The following is a description of a gene set: This event has been computationally inferred from an event that has been demonstrated in another species.<p>The inference is based on the homology mapping from PANTHER. Briefly, reactions for which all involved PhysicalEntities (in input, output and catalyst) have a mapped orthologue/paralogue (for complexes at least 75% of components must have a mapping) are inferred to the other species. studied in species Mus musculus electronically inferred by orthology from the curated human pathway Reactome Pathway: TP53 Regulates Metabolic Genes part of: Transcriptional Regulation by TP53, and this is the list of marker genes: Higd1c, Gpx2, Cox7c, Ywhae, Sesn2, Tsc1, Lamtor5, Cox6a1, Sfn (stratifin), Txnrd1, Prkag1, Lamtor1, Gls2, Ndufa4, Cox5a, Lamtor4, Cycs, Lamtor2, Rheb, Cox4i2, Cox4i1, Prdx1, Cox7a2l, Txn1, Rragc, Cox7a1, Ddit4, Ywhah, Cox6c, Rraga, Cox8c, Cox6a2 (NCBI Gene Id 12862), G6pdx, Prkag3, Prdx5, Cox8a (cytochrome c oxidase subunit 8A)